Given this list of marker genes DPAGT1, GMPPB, COLQ, ALG14, ALG2, GFPT1, LAMB2, here is a description of the gene set: Human Gene Set: HP_RESPONSE_TO_DRUGS_ACTING_ON_NEUROMUSCULAR_TRANSMISSION studied in species Homo sapiens Response to drugs acting on neuromuscular transmission Specific drugs interfere selectively with the different cellular mechanisms involved in neuromuscular transmission (synthesis, storage, release, action and inactivation of transmitter). The response of a patient to a specific drug can therefore be useful information for the differential diagnosis.